Given this list of marker genes TPR, GABBR2, KIF15, GLYCTK, SHANK3, DYRK1A, FOXG1, UBE3A, CDKL5, BRAF, GRIK2, MECP2, DDC, OCA2, NTNG1, ZSWIM6, SMC1A, here is a description of the gene set: studied in species Homo sapiens Tongue thrusting Human Gene Set: HP_TONGUE_THRUSTING Pressing forward of the tongue in the mouth, a retained motoric habit from infantile swallowing patterns